Given this list of marker genes Nt5c3, Nt5c2, Acp3, Nt5c1b, Nt5c3b (NCBI Gene Id 69924), Nt5e, Entpd3, Nt5dc1, Nt5c, Nt5m, Nt5c1a, Nt5dc3, Nt5dc2, here is a description of the gene set: Catalysis of the reaction: a 5'-ribonucleotide + H2O = a ribonucleoside + phosphate. Mouse Gene Set: GOMF_5_NUCLEOTIDASE_ACTIVITY studied in species Mus musculus